The following is a description of a gene set: part of: Potassium Channels Reactome Pathway: Inwardly rectifying K+ channels species: Mus musculus electronically inferred by orthology from the curated human pathway This event has been computationally inferred from an event that has been demonstrated in another species.<p>The inference is based on the homology mapping from PANTHER. Briefly, reactions for which all involved PhysicalEntities (in input, output and catalyst) have a mapped orthologue/paralogue (for complexes at least 75% of components must have a mapping) are inferred to the other species., and this is the list of marker genes: Gnb3, Gngt2, Gnb5, Gng5, Kcnj3, Kcnj1, Gng4, Kcnj12, Kcnj14, Kcnj11, Kcnj2, Gnb2, Gng11 (guanine nucleotide binding protein (G protein), gamma 11), Gng8, Gng10, Gabbr1, Gng3, Kcnj10, Kcnj8, Gng7, Kcnj5, Gngt1